Given this list of marker genes Abcb6, Abcb7, Abcb8, here is a description of the gene set: studied in species Mus musculus This event has been computationally inferred from an event that has been demonstrated in another species.<p>The inference is based on the homology mapping from PANTHER. Briefly, reactions for which all involved PhysicalEntities (in input, output and catalyst) have a mapped orthologue/paralogue (for complexes at least 75% of components must have a mapping) are inferred to the other species. part of: ABC-family protein mediated transport Reactome Pathway: Mitochondrial ABC transporters electronically inferred by orthology from the curated human pathway